The following is a description of a gene set: Mouse Gene Set: GOBP_SULFUR_COMPOUND_BIOSYNTHETIC_PROCESS species: Mus musculus The chemical reactions and pathways resulting in the formation of compounds that contain sulfur, such as the amino acids methionine and cysteine or the tripeptide glutathione., and this is the list of marker genes: Slc35d1, Cryaa, Slc25a16, Ndst2, Thtpa, Ext1, Acsl1 (acyl-CoA synthetase long-chain family member 1), Csgalnact2, Eif2ak3 (NCBI Gene Id 13666), Acss1, Lias, B4galnt3, Acsl5, Acsl6, Slc1a2, Hs3st5, Acly, Dse, Elovl3, Pank3, Ppcs, Slc7a11, Hs6st1, Dip2a, Mmaa, Adi1, Hs6st3, Pgk1, Gstp2, Tcf7l2 (transcription factor 7 like 2, T cell specific, HMG box), B3gat2, Cbs, Pdk2, Glce, Gcdh, Slc25a19, Acss2, Cth, Pdk4, Hs3st4, Mat2a, Hs2st1, Papss2, Slc1a1, Hs3st2, Hs3st3b1, Ndst1 (NCBI Gene Id 74141), Hs3st1, Tpk1, Slc25a42, Fmo3, Vangl2, Bhmt, Elovl5, B3gat3, Mtap, Hs3st3a1, Chpf2, Elovl1, Vdac1, Pdk3, Elovl4, Fmo1, Ggt1, Dcakd, Extl1, Snca, Ggt5, Mlycd, Pank1, Mpc2, Hagh, Mmut, Dld, Mpc1, Pdk1, Acat1, Mgst2, Lipc, Ppcdc, Mat1a, Cytl1, Gstm3, Chst11, Gclm, Gstp-ps, Csad, Tm9sf2, Mettl16, Pank2, Mpst, B4galnt4 (NCBI Gene Id 381951), Mthfd2l, Pdhx, Mri1, Ndst4, Ggt7, Gss, Chpf, Cdo1, Bhmt2, Gclc, Csgalnact1, Ext2, Slc35d2, Galnt3, Apip, Elovl7 (ELOVL fatty acid elongase 7), Mat2b, Sp1, Ctnnb1, Bhmt1b, Slc19a2, Gstm6, Pdha1, Nfe2l2, Xylt2 (xylosyltransferase II), Mtrr, Acsl4, Xylt1, Dlat, Gstp3, Chst12, Hs3st6, Ggt6, Chst7, Hs6st2, Chsy1, Htd2, Ugdh, Enoph1, Coasy, Acot7, Extl3, Pank4, Ndst3, Gstp1, B3gat1, Chst3, Gsta1, Slc35b2, Pxylp1, B3galt6, Chsy3, Slc19a3, Elovl6, Chst13, Bckdk, Pdha2, Gstm1, Mthfd1, Igf1, Mthfr, Pdhb, Papss1, Mtr, Acacb, Acaca